The following is a description of a gene set: species: Homo sapiens Human Gene Set: REACTOME_PRESYNAPTIC_FUNCTION_OF_KAINATE_RECEPTORS Presynaptic function of Kainate receptors, and this is the list of marker genes: GNB4, GNG12, GNB5, GNG13, GNG4, GNB1, PLCB1, GNG3, GNB3, GNG8, PLCB2, GNB2, PLCB3, GNG5, GNGT2, GNG7, GNG11, GNG10, GRIK3, GNGT1, GNG2 (G protein subunit gamma 2)